The following is a description of a gene set: The assembly of a bleb, a cell extension caused by localized decoupling of the cytoskeleton from the plasma membrane and characterized by rapid formation, rounded shape, and scarcity of organelles within the protrusion. Plasma membrane blebbing occurs during apoptosis and other cellular processes, including cell locomotion, cell division, and as a result of physical or chemical stresses. Human Gene Set: GOBP_BLEB_ASSEMBLY species: Homo sapiens, and this is the list of marker genes: LPAR1, MYLK, ANO6, EMP1, LPAR3, P2RX7, EMP3, ANLN (anillin, actin binding protein), PMP22, ROCK1, EMP2